Given this list of marker genes IL1RAP, LRFN4, SHANK1, GRIA1, DLGAP1, HOMER3, APBA3, DLGAP4 (NCBI Gene Id 22839), FLOT2, IL1RAPL1, PPFIBP1 (NCBI Gene Id 8496), NLGN4Y, LIN7A, LRRTM1, LRFN1, NLGN3, SYT10, DLG4, SYT1 (NCBI Gene Id 6857), LRRTM4, SLITRK2, GRM5, STXBP1, PPFIBP2, NRXN2, NRXN3, LRFN3, PTPRD, PPFIA2, PTPRF, GRIN2D, FLOT1, EPB41L3 (NCBI Gene Id 8730), NRXN1, IL1RAPL2, SHARPIN, HOMER1, RTN3, NLGN4X, SYT12, GRIN2C, GRIN2B, SYT9, PPFIA1, LRRTM3, PPFIA3, GRIA3, DLGAP3, APBA2, SLITRK5, DBNL, APBA1 (amyloid beta precursor protein binding family A member 1), CASK, DLG1, NTRK3, SYT2, SIPA1L1, SLITRK4, EPB41, SYT7, SLITRK3, STX1A, EPB41L2, PTPRS, NLGN1, GRIA4, GRIN1 (NCBI Gene Id 2902), SLITRK6, LRRTM2, SHANK2, GRIN2A, LRFN2, DLG3, DLGAP2, LRRC4B, SLITRK1, BEGAIN, PPFIA4, EPB41L5, HOMER2, LIN7B, DLG2, LIN7C, EPB41L1, GRM1, NLGN2, PDLIM5, here is a description of the gene set: Protein-protein interactions at synapses Human Gene Set: REACTOME_PROTEIN_PROTEIN_INTERACTIONS_AT_SYNAPSES species: Homo sapiens